The following is a description of a gene set: The chemical reactions and pathways resulting in the breakdown of a protein or peptide covalently tagged with ubiquitin, via the DesCEND (destruction via C-end degron) pathway. In the DesCEND pathway, C-terminal residues (C-end degrons) in substrates are recognized by Cul2-RING and Cul4-RING E3 ligases, whereupon the substrates are linked to ubiquitin and then delivered to the proteasome for degradation. C-end degrons can be present in full-length proteins, truncated proteins or proteolytically cleaved forms. studied in species Mus musculus Mouse Gene Set: GOBP_UBIQUITIN_DEPENDENT_PROTEIN_CATABOLIC_PROCESS_VIA_THE_C_END_DEGRON_RULE_PATHWAY, and this is the list of marker genes: Rbx1-ps, Cul4a, Klhdc2, Rbx1, Klhdc1, Cul2, Fem1b (NCBI Gene Id 14155), Trpc4ap, Fem1c, Klhdc10, Fem1a, Dcaf12, Fem1al, Klhdc3